The following is a description of a gene set: studied in species Mus musculus from publication Chen Y, Wang X (PMID 31504780) Mouse Gene Set: MIR_467H Genes predicted to be targets of miRBase v22 microRNA mmu_miR_467h in miRDB v6.0 with MirTarget v4 prediction scores > 80 (high confidence targets)., and this is the list of marker genes: Caprin2 (caprin family member 2), Trio, Sap18, Cltb, Cbll1, Rab11a, Gpr45, Hyal4, Washc4, Kcnj6, Kcna2, Neurl4, Raph1, Skida1, Zfp521, Myb, Myrf, Trappc8, Cadps2, Snx5, Zbtb41, Tmc7, Qser1, Mtpn, Srgap1, Mylk, Ube4a, Ssxb10, Fam120c, Dmxl1, Spata6l, Abcc2, Cntn1, Vps29, Tpd52, Lonrf1, Tubgcp4, Gnai1, Dnajc3, Etfrf1, Itgb4, Nipa1, Terb2, Nampt, Sp3 (trans-acting transcription factor 3), Mageb16, Gpm6b, Gja6, Thsd7a, Ms4a5, Arhgap29, Farp2, Znrf3, Cald1, Cwc22, Camk4, Tent4b, Fzd6, Fancc, Pax9 (paired box 9), Saxo2, Atp1b1, Utrn, Zdhhc13, Dimt1, Kdm1b, Ssr1, Crem, Cnot6l, Mstn, Pcdh7, Eif4h, Dera, Arid4b, Katnbl1, Nek7, Wapl